Given this list of marker genes Grin1, Psen1, Itsn1, Epha10, Lyn, Epha8, Vav2, Arpc1b, Epha7, Efna2, Ptk2, Fyn, Efna4 (ephrin A4), Efna3, Arpc3, Efnb1, Ngef, Yes1, Src, Actr2, Epha2, Efnb3, Aph1a, Nck2, Ephb3, Sdc2, Rock2, Mmp9, Arpc2, Epha1, Mmp2, Rasa1, Epha4, Arpc5, Ephb1, Actg1, Efna1, Ephb4, Cdc42, Kalrn, Arhgef7, Aph1b (aph1 homolog B, gamma secretase subunit), Rock1, Arpc1a, Vav3 (NCBI Gene Id 99531), Pak3, Actb, Pak2, Arpc4, Sdcbp, Ephb6, Efnb2, Ephb2, Arhgef28, Rhoa, Hras, Psenen, Actr3, Pak1, Efna5, Rac1, Git1, Ncstn, Epha6, here is a description of the gene set: Mouse Gene Set: REACTOME_EPH_EPHRIN_SIGNALING EPH-Ephrin signaling species: Mus musculus